The following is a description of a gene set: Abnormal thumb morphology An abnormal structure of the first digit of the hand. species: Homo sapiens Human Gene Set: HP_ABNORMAL_THUMB_MORPHOLOGY, and this is the list of marker genes: COL2A1, ADH5, GTF2IRD2, SALL1, SHH, SIN3A, RNU4ATAC, MEGF8, FGFR2, MYCN, LIMK1, B3GLCT (NCBI Gene Id 145173), ANKRD11, DSE, RPL15, PHGDH, PIK3CD, RBM8A, TMEM107 (transmembrane protein 107), SETBP1, CWF19L1, OSGEP, NSD2, PYCR2, BLTP1, GJA8, SVBP, STX1A, NEK1, FANCA, FANCF, LONP1, HNRNPR, CDC45, MYH3, RAD21, WNT5A, BMPR1A, NELFA, L1CAM, CREBBP, GATA4, TDO2, BMP2, ECEL1 (endothelin converting enzyme like 1), PALB2, USP9X, DPH2, DVL3, CRLF1, KAT6B, RPS26, TSR2, CHST14, BAP1, FRA10AC1, RFC2, EZH2, PHF8, PKDCC, ACTA1, ZSWIM6, FANCB, BUD23, ZNF668, SUMF1, DHODH (dihydroorotate dehydrogenase (quinone)), GPC4, RPL31, FIBP, SLC26A2, ADA2, NSUN2 (NOP2/Sun RNA methyltransferase 2), DYNC2I1, CTCF, TMEM270, PCDHGC4, COL6A3, ALG3, TP53RK, FBN2, LIG4, DHCR7, FGFR1, BMP4, LAGE3, PACS1, SF3B4, FLNA, EPB41L1, RPL27, RPS15A, CLIP2, WDR73, PTRH2, HOXA13, BRCA2 (NCBI Gene Id 82716), GTF2IRD1, RPL35A, ZNF699, CUL3, BPTF, ATP6V1B2, B9D1, DYNC2I2, CANT1, ALG13, FKBP6, RPS7, MAFB, DACT1, HPGD, CHST3, SMPD4, YRDC, ACTG1, LTBP2, LIFR, SON, SMO, CDC42, ALG12, B3GAT3, RECQL4, COL12A1, TNNT3, RAB23, FANCI, GPKOW, MED12, BRIP1 (NCBI Gene Id 83991), ZNF462, ROR2, OTUD6B, PIGY, BHLHA9, RPL18, NIPBL, HYLS1, RAD51, XYLT1, RPS19, HDAC8, H3-3A, MSL3 (NCBI Gene Id 25867), SYNE1, NUP107, PLXND1, RTL1, PQBP1, INTU, SNIP1 (NCBI Gene Id 79753), FIG4, CRIPT, SF3B2, MED25, MEG3, RPS24, METTL27, KLHL40, SATB2, FANCD2, COL6A1, DNM1L, TAPT1, ANKLE2, PTCH1, SALL4, TWIST1, PIGG, NPR3, TRIO (NCBI Gene Id 7204), CHSY1, IHH, ZC4H2, FGF9, KCNN3, BPNT2, FANCC, MSX2, RERE, LETM1, COG7, FGF10 (NCBI Gene Id 2255), GJA1 (NCBI Gene Id 7953), TCTN2, TMEM237, DHX30, RPGRIP1, VAC14, HEPACAM, TAF6, CBFB, SMC1A, CHD7, DONSON, TOR1A, TBX5, CTBP1, MAD2L2, PTH1R, DVL1, GNAS (NCBI Gene Id 82944), UBAP2L, RPL26, TP63, NSD1, WDR4, MGP, PIGB, RPS27, NCF1, EED, CNOT1, LMOD3, ALG9, NOG, SMOC1, BAZ1B, ECE1, EFTUD2, ADGRG6, SHMT2 (NCBI Gene Id 6472), PCNT, DLX5, CPLANE1, BRCA1, CEP290, PRKD1, MKS1, RECQL, RAD51C, TXNDC15, TFAP2A, FRAS1, CC2D2A, RPL5, MYL11, RPS17, FGFR3, ACVR1, EXOSC9, ERCC1, AP4M1, RPGRIP1L, ALX4, KLHL41, EIF4A3, RPS20, PSMD12, GLI3, H3-3B, RPL35, STUB1 (STIP1 homology and U-box containing protein 1), CHN1, RLIM, ELN, SIAH1, DNAJC30, RPL8, UBE2T, SPART, KCNH1, PRKG2, SLC9A6, RNU4-2, EXTL3, COL6A2, SLC35B2, CRPPA, KCTD1, NALCN, PCGF2, IFT56, FANCM, EP300, VPS35L, LMBR1, KIF7, NDE1, MGAT2, NEB, APC (NCBI Gene Id 324), NXN, RFWD3, TCTN1, PAH, POGZ, SRCAP, MYBPC1, SUZ12, ESCO2, GJA5, ADNP, ATAD1, ERI1, ZIC3, FANCE, ZEB2, GLI1, ACTB, TMEM231, DYNC2H1, TNNI2, GPC3, FLNB (filamin B), KATNB1, RB1, HOXD13, DLK1, FBLN5, RELN, G6PC3, TBC1D24, RFT1, TMEM216, MEIS2, BCOR, ACAN, B3GALT6, SMC3 (NCBI Gene Id 9126), GTF2I, RRAS2, PTEN, IFT80, SLX4, ALDH18A1, WDR26, TCTN3, MAP3K7, KNSTRN, GON7, LRP4, CSPP1, FZD2, BRD4, RUNX2, BICD2, CLIC2, RSPO2, MIR17HG, XRCC2, VPS37D (NCBI Gene Id 171020), NONO, PUF60, RPS29, TRPM3, REV3L, GNB1, TGDS, RPL9, KDM1A, OFD1, EXOSC2, FANCL, TMEM67, B9D2, FANCG, GATA1, EIF4H, SOX9, ADAMTS17, OPA3, FGFRL1, RAB34, NKX3-2, RPS10, CPLX1 (NCBI Gene Id 10815), GDF5, WIPI2, RIPK4, PPP2R3C, ERCC4, ADAMTS10, TPRKB, BICRA, INPPL1, PIGF, TBL2, TPM2, NUP133, CHST11, WDR35, BMPR1B, NAA10, ZMYM2, RPS28, ROBO1, NEK9, RPL11, LAMA5, FBN1, MAN2C1, CILK1, LMNB2, FILIP1, HEATR3